The following is a description of a gene set: Neighborhood of IL2RB interleukin 2 receptor, beta in the GNF2 expression compendium Neighborhood of IL2RB species: Homo sapiens Human Gene Set: GNF2_IL2RB, and this is the list of marker genes: KIR3DL3, GZMA, IL18RAP, CTSW, CD244, GNPTAB, CD160, GZMM, ASCL2, KLRC3, CCL4, NCR3, SUN2, PTPN4, S1PR5, RUNX3, GZMH, NKG7, KIR2DS4, TTC38, GNLY, ADGRG1, PTGER2, RAB29, LAIR2 (NCBI Gene Id 3904), PRKCH, KIR3DL1, TBX21, SPON2, KIR2DL1, KLRD1, KIR3DL2, CST7, PTGDR, IL2RB, MYOM2, PRF1, MATK, CX3CR1, XCL2, ABHD17A (abhydrolase domain containing 17A, depalmitoylase), ARL4C, KLRF1, KIR2DS2, CD7, CD247